Given this list of marker genes SLC25A25, CDH17, TSR2, PIAS2, LGALS3BP, EDN1, TREX1, EREG, CISH, ILDR1, FGL2, SMARCE1, SLC7A11, GK, MAP3K8, CRYBB3, CACNA2D1, TRIB1, CCL5, EMP1, IFIT3, TXNRD3, TIMP1, NOC4L, EXT1, IFNG, MAFF, GBP2, PHYHIPL, SLC15A3, HBEGF, ELP5, HSD11B2, DCUN1D5, ST6GALNAC4, ADORA2B, SAA1, LITAF, PEX11A, IFIT2, SRGN, CD164, ID2, TPST1, IL33, BASP1, FERMT2, SOAT2, RUNX3, CXCL11, TXNRD1, WIZ, TNFRSF9, SELP, IFI35 (NCBI Gene Id 3430), DAXX, IL22, ADM, ALPL, FPR2, ATP8A2, DDX21, MMP3, EZR, PTPRM, SPSB1, MMP13, SMIM3, SRY, GUCY2D, NPPC, TFPI2, CZIB, EHD1, IRF7, HK2, CCN1, RAB20, IFNA1, GNL2, RTP4, ARSI, EBAG9, ALDH1A2, HIVEP3, IFIH1, NR6A1, RRP1B, CIRBP, RAP1B, CCL2, SH3GL3, SDC4, B3GALNT1, TBRG1, GZMB, IL2RA, PTPN12, TAPBP, RAMP3, UPP1, VDR, HDC, TDRD7, CXCL9, NFIL3, MAPK6, ACOD1, NOP16, TM4SF1, ZBP1, CILP2, CSF3, PLSCR1, LIPG (lipase G, endothelial type), ADAR, NLE1, PRICKLE1, SOD2, SLC25A22, AEN, IL1RN, PTGS2, CD44, NUPR1, ZNFX1, RDH10, CD276, KLF6, BCL2L11, STAT5A, HAS1, EPPK1, PPA1, MYCN, TUBB6, ADAMTS4, C11orf96, FURIN, PPAN, APOD, HMGCR, DUSP16, ASB4, INHBB, PRSS44P, GLIPR2, RIN2 (Ras and Rab interactor 2), MISP, DOP1B, PRMT6, LARP1, ZBTB32, IL15, VAPA, PML, NTS, FGD6, MAP2K4, TNFSF10, LIF, CCL13, SPRED1, DDX24, BATF2, NIBAN1, NAA20, LAMC2, MARCKSL1, IL10, KRTAP4-11, ZFAND5, CCL4, IL1A, PLAT, CCL7, OAS2, ACSL4, SIX3, SOCS1, CDKN1A, HRH2 (histamine receptor H2), MT1E, AVPR1A, RHOU, MX2, HIF1A, MEDAG, CCL11, CPEB2, OGFR, TASOR2, USP18, CYBB, HCK, KCNE4, GEM, CLIC4, CD14, EPB41L4A, here is a description of the gene set: studied in species Homo sapiens Human Gene Set: GSE9601_NFKB_INHIBITOR_VS_PI3K_INHIBITOR_TREATED_HCMV_INF_MONOCYTE_DN from publication Chan G, Bivins-Smith ER, Smith MS, Yurochko AD (PMID 18003728) Human cytomegalovirus induces a pro-inflammatory monocyte following infection and we have evidence that NF-κB and phosphatidylinositol 3-kinase are key mediators in this early activation. To begin to address how these signalling pathways are responsible for the rapid activation of infected monocytes, we examined the role these pathways played in the transcriptome of infected monocytes. Global transcriptional profiling using cDNA microarrays revealed a significant number of genes, including inflammatory genes, were regulated in a NF-κB- and/or PI(3)K-dependent manner, identifying these pathways as key cellular control points in the conversion of monocytes to an activated pro-inflammatory state following HCMV infection. Genes down-regulated in monocytes after HCMV infection: BAY 11-7082 versus Ly294002.